Given this list of marker genes ZNF354C, TMEM106B, CILK1, FAXC, ZSWIM6 (zinc finger SWIM-type containing 6), AFDN, AQP4, PTCD2, WDR33, ABCC8, HOXA9, RETREG1, ZNF546, ARFIP1, SENP5, DOT1L, KCNC4, ADAM17, SDCBP2, COQ2, FBXO24, TRIM59 (NCBI Gene Id 353185), BNC1, RBFOX1, SLC37A4, ADHFE1, ACOT13, SOX9, MED13, SKP2, GALNT3, SLC25A25, USPL1, LCA5, PRCP, RAB40B, NLRP4, CELF2, SLC2A13, FFAR4, ADCY1, MAN1A1, OXTR, GRM5, TMTC3, THSD7A, PGRMC2, CCNY, DCAF5, CCNG1, ZNF792, FGF13, SNRNP27, DCLK3, PTAR1, LPAR4, GPR75, SF3B1, C18orf54, CASK, JAG1, ADGRG7, SYT16, TNRC6B (NCBI Gene Id 23112), PARP8 (poly(ADP-ribose) polymerase family member 8), TXLNB, HDGFL3, UBE4B, TRIM33, DTNBP1, TRIM52, SIKE1, CLEC4D, ZEB1, RRP15, DYNC1LI2, CDR2L, NAA50, ARMC8, AEBP2, TBC1D9, SH3BGRL2, DEK (NCBI Gene Id 7913), PTBP3 (polypyrimidine tract binding protein 3), PKP4, CMPK1, MYSM1, SMIM14, RAP2C, DAZAP2, LAMP2, RSF1, TCF12, SERPINB7, RUNX1T1, PHYHIPL (phytanoyl-CoA 2-hydroxylase interacting protein like), CTBP2, LDLRAD3, YTHDF3, PRKAG2, FHIP1A, DCUN1D5, PRKAR1A, SLA2, TPH2, KLF10, FAT3, TMEM74, UTY, CIT, TRNT1, RPE, FAT1, NLK, SIPA1L2, FGF7, PAK5, FABP7, CCDC28A-AS1, PAFAH2, DOCK11, RNF144A, ARMH4, SC5D, AOX1, NUCKS1, RC3H1, CCNJ, ZNF225, ZBTB20, GPR15, LRRC59, RNF111, LARP4, SOSTDC1, ADH7, APPL1, QKI, DSCC1, SLC30A4, G3BP1, VPS53, RB1CC1, SYNPO2, here is a description of the gene set: Genes predicted to be targets of miRBase v22 microRNA hsa-miR-4762-5p in miRDB v6.0 with MirTarget v4 prediction scores > 80 (high confidence targets). species: Homo sapiens from publication Chen Y, Wang X (PMID 31504780) Human Gene Set: MIR4762_5P